The following is a description of a gene set: part of: RNA Polymerase III Transcription Initiation The type 2 promoters can recruit TFIIIC without the help of TFIIIA because TFIIIC binds directly to the A and B boxes. As for the type 1 promoters, this then allows the binding of Brf1-TFIIIB and RNA polymerase III. Importantly, in the yeast system, once Brf1-TFIIIB has been recruited to type 1 or 2 promoters, TFIIIA and/or TFIIIC can be stripped from the DNA with high salt or heparin treatment. Brf1-TFIIIB remains bound to the DNA and is sufficient to direct multiple rounds of transcription. Reactome Pathway: RNA Polymerase III Transcription Initiation From Type 2 Promoter studied in species Homo sapiens, and this is the list of marker genes: POLR2K, POLR1C, POLR2E (NCBI Gene Id 5434), POLR3D, POLR3K, GTF3C6, POLR3G, GTF3C5, POLR3E, BDP1, POLR3C, GTF3C2, POLR2L, GTF3C1, POLR2F, TBP, POLR3A, POLR1D, POLR3B (RNA polymerase III subunit B), CRCP, POLR3GL (NCBI Gene Id 84265), GTF3C3, POLR2H, BRF1, GTF3C4, POLR3H, POLR3F